Given this list of marker genes CFAP43, PCNX1 (NCBI Gene Id 23690), FCRLA, ABLIM3, PTGES2, VWF, GPR35, UBE3B, SHROOM3, FAM151A, HCRT, CYS1, NKD1, AOAH, PCP2, VDAC1, TULP2, FAM149A, MCAM, PRSS53, NRXN2, PEBP1, SLC25A34, PIWIL2, BCL7C, NOTUM, RUSC2, CIMIP7, C4BPB, SRF, KRTAP19-5, TSNAXIP1, TMEM184A, GPRIN1, UBQLNL, SETD1A, COL10A1, DHH, SENP3, PAPOLB, SLC6A5, KCNG2, RNF144B, HSD17B10, KRTAP26-1, CREB5, KLC4, COX16, NACC1, TINF2, RBMX2 (NCBI Gene Id 51634), RAB5C, SNAPC2, DTNB, SIGLEC1, MAML2, TCEAL9, CAVIN3, PLA2G4E, MARCKS, CGN, HS2ST1, PLCD1, SCN2B, ELN, HEMGN, RAB31, TRAPPC9, POP7, EXOC3L4, LRFN1, FNDC11, GUCA1B, RSPH4A, SVEP1, TULP1, TGIF2LX, AFAP1L2, KALRN, GABRA2, EPC1, ELF3, RASGRP4, MED17, BDNF, ATF7, ZNF483, MAB21L1 (mab-21 like 1), RPE65, UACA, CFAP97D1, CYB5RL, SLC22A13, VCPKMT, MDGA2, CELA2A, GSDMA, KLRC3, BAALC, DENND2A, H1-7, KRT23 (NCBI Gene Id 56668), GRIA1, SST, RAB3C, SH2D6, MRPL49, TNNT1, USE1, FBXO41, IBSP, LRRC47, PTPN2, CCDC184, TMC5, OTUD7A, PTCHD4, SCUBE3, NELL2, FAM3D, ASTE1, MYORG, RCC1, AIFM2, ADAM7, SPATA7, LANCL3, GAST, LRTM1, DEGS2, SHOX2, CLDND2, MPL, CCDC85A, SYNGR1, PLCZ1, TIMM22, VSTM5, PDGFRA, ADRA2C, RAI14, OLFM1, RAVER1, CWH43, FGG, PMP22 (NCBI Gene Id 5376), TMEM236, TTPA, BPIFA1, LZTS3, RNF222, NARS2, MIR124-1HG, SORD, POU3F4, KAZN, PPP3R2, PTPN18, CRISP3 (NCBI Gene Id 10321), C3, ADAD2, TOP3A, ZXDB, SCAMP5, PPP1R15B, PPIB (peptidylprolyl isomerase B), MSMB, ZNF213 (NCBI Gene Id 9233), ONECUT3, MEIG1, STXBP6, PROKR1, MCM3, OC90, CNTN4, COX7A2, C15orf62 (NCBI Gene Id 648327), TDO2 (NCBI Gene Id 6999), COX14, C4B, DPH3, TRIM63, IL34, TMEM79, PHLPP1, GABRG2, CAPN13, HEMK1, COQ7, PCDH19, SYT3 (NCBI Gene Id 84258), ARHGEF26, MUC13, LGI2, CMTM8, GPR27, SEMA3A (NCBI Gene Id 63232), ENTPD8, here is a description of the gene set: Effects of IL-4 on CD8 T cells functions are largely unknown. IL-4 induces survival and proliferation of CD8 T cells, but several studies suggest that IL-4 could also affect several functions of CD8 T cells such as cytotoxicity. Our team has shown that IL-4 repress the expression of Ccl5 in vitro. To define more precisely the impact of IL-4 on CD8 T cells, we performed a whole genome expression microarray analysis of naive and memory CD8 T cells cultured in presence or absence of IL-4. This approach allowed us to define the IL4-gene-expression signature on CD8 T cells. from publication Ventre E, Brinza L, Schicklin S, Mafille J, Coupet CA, Marçais A, Djebali S, Jubin V, Walzer T, Marvel J (PMID 22942430) Genes up-regulated in comparison of memory CD8 T cells versus those treated with IL7. studied in species Homo sapiens Human Gene Set: GSE32423_CTRL_VS_IL7_MEMORY_CD8_TCELL_UP